The following is a description of a gene set: Mouse Gene Set: GOBP_CELLULAR_RESPONSE_TO_L_GLUTAMATE studied in species Mus musculus Any process that results in a change in state or activity of a cell (in terms of movement, secretion, enzyme production, gene expression, etc.) as a result of a L-glutamate(1-) stimulus., and this is the list of marker genes: Gria1, Baiap2, Amigo1, Fyn, Prkn, Abcb1a, Lmnb1, Grin2d, Hpca